Given this list of marker genes SLIT3, WNT3A, WNT5A, VEGFA, DSCAM, NRP2, SLIT1, HDAC6, SEMA3A, SLIT2, PLXNA4, CXCL12, RYK, NRP1, ALCAM, MEGF8, BMPR2, PLXNA3, SEMA5A, WNT3, SEMA3F, here is a description of the gene set: Any neuron projection extension that is involved in neuron projection guidance. Human Gene Set: GOBP_NEURON_PROJECTION_EXTENSION_INVOLVED_IN_NEURON_PROJECTION_GUIDANCE studied in species Homo sapiens